The following is a description of a gene set: An endosomal compartment that is part of the post-synapse. Only early and recycling endosomes are typically present in the postsynapse. Human Gene Set: GOCC_POSTSYNAPTIC_ENDOSOME species: Homo sapiens, and this is the list of marker genes: PIK3C3, GRIPAP1, VPS26B, ABHD17A, SH3GL3, STX12, MKLN1, ANP32E, CLSTN1, AGAP1, ABHD17B, ZDHHC2, RAB11FIP3, SNX6, NSG1, AKAP5, SNX27, TFRC, RAB11A, EEA1, AP3M1